The following is a description of a gene set: studied in species Mus musculus Mouse Gene Set: GOBP_MOTOR_LEARNING Any process in which an organism acquires a novel neuromuscular action or movement as the result of experience., and this is the list of marker genes: Taco1 (translational activator of mitochondrially encoded cytochrome c oxidase I), Git1 (NCBI Gene Id 63992), Adgrb3, Dkk1, Clstn3, C1ql1, Gpr88, Ube3a, En1